The following is a description of a gene set: Human Gene Set: GOCC_CAMP_DEPENDENT_PROTEIN_KINASE_COMPLEX An enzyme complex, composed of regulatory and catalytic subunits, that catalyzes protein phosphorylation. Inactive forms of the enzyme have two regulatory chains and two catalytic chains; activation by cAMP produces two active catalytic monomers and a regulatory dimer. species: Homo sapiens, and this is the list of marker genes: PRKAR1A, PRKACB, PRKACA, PRKX, AKAP14, AKAP4 (A-kinase anchoring protein 4), PRKAR2B, PRKACG, PRKAR2A, PRKAR1B, PRKY